The following is a description of a gene set: Eye of the tiger anomaly of globus pallidus Human Gene Set: HP_EYE_OF_THE_TIGER_ANOMALY_OF_GLOBUS_PALLIDUS The presence, on T2-weighted magnetic resonance imaging, of markedly low signal intensity of the globus pallidus that surrounds a central region of high signal intensity in the anteromedial globus pallidus, producing an eye-of-the-tiger appearance. The sign is thought to represent iron accumulation in the globus pallidus. species: Homo sapiens, and this is the list of marker genes: C19orf12, WDR45, FA2H, NUDT2, FTL, DLAT, PLA2G6, FTH1, VPS41, PANK2, COASY (NCBI Gene Id 80347)